The following is a description of a gene set: Genes predicted to be targets of miRBase v22 microRNA mmu_miR_103_3p, mmu_miR_107_3p in miRDB v6.0 with MirTarget v4 prediction scores > 80 (high confidence targets). studied in species Mus musculus from publication Chen Y, Wang X (PMID 31504780) Mouse Gene Set: MIR_103_3P_MIR_107_3P, and this is the list of marker genes: Eif4b, Chd2, Dicer1, Fam98a, Piezo1, Phyhipl, Dync1li2, Snrk, Cdk6, Armc1, Gpr63, Csnk1g3, Ppip5k2, Prrt2, Rnf38, Mef2d, Prkce, Npas3, Gnpnat1, Axin2, Zfpm2, Hdgfl3 (HDGF like 3), Cds2, Kif3b, Adamtsl3, Ino80d, Rab11fip2, Herc2, N4bp1, Itpr1 (NCBI Gene Id 18544), Tmem33, Cyp3a41a, Nf1, Rai14 (NCBI Gene Id 75646), Ncor1, Camkk1, Tgfbr3, Jakmip2, Dynlt3, Gabrg2, Sec24b, Fermt2, Clip1, Bach2, Arih1, Sbno1, Ppp2r3c, Mlst8, Zhx1, Gga3, Ywhah, Sall1, Gpc6, Atf7, Cab39, Eva1a, Coro2b, Tnpo1, Bcl11a, Fgf5, Six4, Ubr4, Cyb5r4, Rab40b, Pdlim1, Acvr2b, Pik3cb, Gabbr1 (NCBI Gene Id 54393), Prr14l, Ccnyl1 (NCBI Gene Id 98719), Cpne3, Avl9, Cpeb3, Ralgps1, Zfp449, Rab1b, Tbkbp1, Otud4, Acbd3, Apba1, Sptan1, Ppp4r3b, Elac1, Unc80, Flot2, Zcchc2, Ror1, Slc45a4, Celsr2, Cdk14, Nrip3, Abl2, Pnisr, Pabpc1l, Tmem178b, Znrf2, Snx12, Herc6, Iars1, Fam117b, Thada, Usp42, Spats2l, Hacd2, Zdhhc9, Kif21a, Htr4, Lpp, Hykk, Twf1, Fbxw7, Prkg1, Aste1, Kdm7a, Nrp2, Kif23, Fezf1, Ahsa2, Sun2, Sox6, Cyp3a41b, Grpel1, Pde3b, Gpcpd1, Nedd9, Ptpn4, Ndel1, Zfp280d, Nfia, Lrrc4c, Pus7l, Rab10, Osbpl6, Ppp6c, Ago1, Tmem45b, Slain2, Nol4l, Kpna1, Nectin1, Ppp2r5a, Cc2d1b, Ppp6r2, Lats1, Plcxd2, Cntnap1, Pth, Ppm1e, Mapk8, Hic2, Kcna2, Nktr, Ptprm, Zbtb39, Faf2, Mrpl53, Cacna2d1, Pappa2, Capns2, Wnt3a, Phf20, Ube2a, Agfg1, Ube2r2, Fgf10, Med26, Cant1, Zfp711, Cyp3a11, Tnrc6b (trinucleotide repeat containing 6b, NCBI Gene Id 72625), Slitrk1, Cav1, Chd1, Shtn1, Traf3, Ano3, Zbtb10 (NCBI Gene Id 99802), Shcbp1, Ago4